The following is a description of a gene set: GRB7 events in ERBB2 signaling species: Homo sapiens Human Gene Set: REACTOME_GRB7_EVENTS_IN_ERBB2_SIGNALING, and this is the list of marker genes: ERBB3, GRB7, NRG1, NRG2, ERBB2